The following is a description of a gene set: species: Mus musculus Human infertility and recurrent pregnancy loss caused by implantation defects are poorly understood. Hoxa-10-deficient female mice have severe infertility and recurrent pregnancy loss due to defective uterine implantation. Gene expression profiling experiments reveal that Hoxa-10 is an important regulator of two critical events in implantation: stromal cell proliferation and local immunosuppression. At the time of implantation, Hoxa-10 mediates the progesterone-stimulated proliferation of uterine stromal cells. Hoxa-10 mutants express a stromal cell proliferation defect that is accompanied by quantitative or spatial alterations in the expression of two cyclin-dependent kinase inhibitor genes, p57 and p15. Hoxa-10 deficiency also leads to a severe local immunological disturbance, characterized by a polyclonal proliferation of T cells, that occurs in place of the normal progesterone-mediated immunosuppression in the periimplantation uterus. from publication Yao MW, Lim H, Schust DJ, Choe SE, Farago A, Ding Y, Michaud S, Church GM, Maas RL (PMID 12554760) Genes co-regulated in uterus during a time course response to progesterone: SOM cluster 17. Human Gene Set: YAO_TEMPORAL_RESPONSE_TO_PROGESTERONE_CLUSTER_17, and this is the list of marker genes: C8orf82, TMEM160, MRPL21, LSM4, NDUFB6, CRYGD, COPS6, EIF1AX, DDT, ABRACL, EI24, UBA1, SAE1, GCLM, C11orf54, PRELID1, INPP5A, PUF60, CKS1B, DDX54, MARCKSL1, TCEA1, GNG10, HNRNPD, MRPS15, TPM4, PARL, XRCC5, RXYLT1, PSMD13, NDUFS3, ARL3, GSTP1, UQCRQ, TMEM109, SLC39A4, BCAP29, MRPL58, NDUFS6, CMBL (NCBI Gene Id 134147), PIAS3, MDH2, RNF7, ADSL, CENPB, CAPN2, DNAJC19 (NCBI Gene Id 131118), POLR3K, EIF4A3 (eukaryotic translation initiation factor 4A3), TUBB, DLGAP4, CNIH1, MRPS14, SERPINA1, SERF2, HACD3, LRPAP1, COQ7, CKB, LSM7, SLIRP, GOSR2, TMED10, RUVBL1, TXNRD1, MAPKAPK2, CALM1, MRPL36, FUCA1, UBE2S, EEF1AKMT1, COPS5, STUB1, ERP29, SAMM50, RAMP2, NDUFB9, FAM162A, TNFAIP1, MAP3K7, PLPP1, WTAP, KRT10, USP1, NAA10, ARL2BP, NME2, MRPL18, DCTN2, BPGM, URI1, CSNK2B, DOHH, YIPF5, TALDO1, IFI35, EXOC7, EIF4E2, MRPS22, AURKAIP1, ALG5, MRPL2, DDOST, LAMTOR1, PDAP1, GRPEL1, PSMB7, NDUFA11, TOR2A, ARF4, PSMB6, DRAP1, MRPS11, TRAM1, UBL4A, NAP1L1, TIMM13, TWF2, PSMD14, STARD7, KRTCAP2, ROMO1, AQP4, NDUFAB1, LYPLA1, TPP1, CCDC12, MRPL34, SET, HMBS, ACTB, SMDT1, ERH, PHB2, MTIF2, UFC1, FKBP1A, MRPL51, CORO1C, RPN2, FAF1, HSD17B12, DPP3, IMPDH2, PDCD2, VDAC3, TOMM70, SDHB, CMPK1, PSMA7 (NCBI Gene Id 5688), PSMD8, SRSF9, MRPL16, ALDH9A1, TGFB1I1, ERCC3 (ERCC excision repair 3, TFIIH core complex helicase subunit), HSD17B4 (NCBI Gene Id 3295), DDX1, EVL, YJU2, SLC39A9, NDUFV2, PTDSS1 (NCBI Gene Id 9791), MRPS34, LIAS, NDUFB7, MRPS12, HMGCS1, PC, CLPB, BAG1, SLC25A39, CIAO2B, AKT1, SMAP1, LMNA (NCBI Gene Id 7816), RPS6KA4, CYB5R1, PSMG1, TRAPPC4, CDK4, NR2F6, COPE, MRPS7